The following is a description of a gene set: part of: G-protein mediated events Stimulatory G proteins activate adenylate cyclase, which drives the conversion of cAMP from ATP and in turn activates cAMP-dependent protein kinase and subsequent kinase pathways. species: Homo sapiens Reactome Pathway: Adenylate cyclase activating pathway, and this is the list of marker genes: ADCY5, GNAL, ADCY2, ADCY7, ADCY1, ADCY6, ADCY4, ADCY9, ADCY8, ADCY3